The following is a description of a gene set: In this study, an extensive analysis was conducted to define meta-programs (MPs) capturing intra-tumor heterogeneity across a spectrum of tumor types. The approach utilized non-negative matrix factorization (NMF) to analyze each cell type separately within individual tumor samples. This involved the analysis of malignant cells, macrophages, fibroblasts, endothelial cells, epithelial cells, T-cells, and B-cells. NMF was executed with varying parameter values (K=4, 5, 6, 7, 8, 9), thereby generating 39 programs for each cell type per sample. Each NMF program was summarized by the top genes based on NMF coefficients.\nRobust MPs were then delineated for each cell type using a set of stringent criteria, including recurrence within the same tumor, similarity to programs in other tumors, and non-redundancy within a tumor. Subsequently, these robust NMF programs were clustered (per cell type) based on Jaccard similarity, leading to the identification of MPs associated with each cell type.\nTo enhance the quality of the MPs, a refinement steps were undertaken, involving the removal of MPs suspected of reflecting low-quality data (with an overrepresentation of ribosomal proteins or mitochondrial-encoded genes), single-study inclusion, or similarity to miss-annotated cell types. studied in species Homo sapiens from publication Gavish A, Tyler M, Greenwald AC, Hoefflin R, Simkin D, Tschernichovsky R, Galili Darnell N, Somech E, Barbolin C, Antman T, Kovarsky D, Barrett T, Gonzalez Castro LN, Halder D, Chanoch-Myers R, Laffy J, Mints M, Wider A, Tal R, Spitzer A, Hara T, Raitses-Gurevich M, Stossel C, Golan T, Tirosh A, Suvà ML, Puram SV, Tirosh I (PMID 37258682) Genes upregulated in subsets of cells of a given type within various tumors Human Gene Set: GAVISH_3CA_METAPROGRAM_EPITHELIAL_ALVEOLAR, and this is the list of marker genes: TCIM, NNMT, HOPX, SLC34A2 (solute carrier family 34 member 2), ABCA3, LPCAT1, PLA2G1B, SFTA3, MFSD2A, NAPSA, CXCL2, AK1, PGC, PIGR, MALL, AQP1, CA2, ALPL, HLA-DPB1, HLA-DRB1, NPC2, SCGB3A1, TFPI, C16orf89, WIF1, SERPINA1, C3, RNASE1, SFTA2, HLA-DPA1, CYB5A, CD74, AQP3, FABP5, MUC1, SFTPB, PEBP4, LRRK2, SFTPD, DBI, C4BPA (complement component 4 binding protein alpha), LAMP3, SFTPC, SCGB3A2, HLA-DRA, CTSH, SFTPA2, CXCL17, SLPI, SFTPA1